Given this list of marker genes COL3A1, COL11A1, COL11A2, COL4A1, COL12A1, COL9A1, COL23A1, COL21A1, COL16A1, COL13A1, COL5A3 (collagen type V alpha 3 chain), COL27A1, COL18A1, COL25A1, COL26A1, COL20A1, COL9A3, COL5A1, COL6A5, COL7A1, COL4A5, COL4A6, COL8A2, COL5A2, COL24A1, COL1A2, COL22A1, COL14A1, COL9A2, COL8A1, COL6A1, COL4A4, COL6A3, COL6A6, COL28A1, COL4A2, COL10A1, COL19A1, COL1A1, COL17A1, COL4A3, COL6A2 (collagen type VI alpha 2 chain), COL2A1, COL15A1, here is a description of the gene set: studied in species Homo sapiens Reactome Pathway: Collagen chain trimerization The C-propeptides of collagen propeptide chains are essential for the association of three peptide chains into a trimeric but non-helical procollagen. This initial binding event determines the composition of the trimer, brings the individual chains into the correct register and initiates formation of the triple helix at the C-terminus, which then proceeds towards the N-terminus in a zipper-like fashion (Engel & Prockop 1991). Most early refolding studies were performed with collagen type III, which contains a disulfide linkage at the C-terminus of its triple helix that acts as a permanent linker even after removal of the non-collagenous domains. <br><br>Mutations within the C-propeptides further suggest that they are crucial for the correct interaction of the three polypeptide chains and for subsequent correct folding (refs. in Boudko et al. 2011). part of: Collagen biosynthesis and modifying enzymes